The following is a description of a gene set: species: Mus musculus Reactome Pathway: PKA activation electronically inferred by orthology from the curated human pathway part of: PKA-mediated phosphorylation of CREB This event has been computationally inferred from an event that has been demonstrated in another species.<p>The inference is based on the homology mapping from PANTHER. Briefly, reactions for which all involved PhysicalEntities (in input, output and catalyst) have a mapped orthologue/paralogue (for complexes at least 75% of components must have a mapping) are inferred to the other species., and this is the list of marker genes: Adcy5, Adcy7, Calm1, Prkar1b, Prkaca, Prkar2b, Prkacb, Adcy8